Given this list of marker genes DLG4, GRIN2C, NLGN1, BAIAP2 (BAR/IMD domain containing adaptor protein 2), RIMS1, PTK2B, STX1A, SHANK3, ADRB2, GRIN2A, RGS4, APP, NLGN3, GRIN1, DVL1, CHRNA7, NRXN1, TBC1D24, CUX2, SSH1, NLGN2, RELN, WNT7A, NETO1, GRIA1, GRIN2D, SHANK1, PRKCZ, RIMS2 (NCBI Gene Id 9699), PRKAR1B, PTEN, STX1B, GRIN2B, here is a description of the gene set: Any process that enhances the establishment or increases the extent of the excitatory postsynaptic potential (EPSP) which is a temporary increase in postsynaptic potential due to the flow of positively charged ions into the postsynaptic cell. The flow of ions that causes an EPSP is an excitatory postsynaptic current (EPSC) and makes it easier for the neuron to fire an action potential. species: Homo sapiens Human Gene Set: GOBP_POSITIVE_REGULATION_OF_EXCITATORY_POSTSYNAPTIC_POTENTIAL